Given this list of marker genes FKTN, RAMP1, GOLGA2, ABCA2, CHP1, MGAT4D, SLC51B, ACER2, CCDC134, here is a description of the gene set: studied in species Homo sapiens Human Gene Set: GOBP_REGULATION_OF_PROTEIN_GLYCOSYLATION Any process that modulates the frequency, rate or extent of protein glycosylation. Protein glycosylation is the addition of a carbohydrate or carbohydrate derivative unit to a protein amino acid, e.g. the addition of glycan chains to proteins.